The following is a description of a gene set: Human Gene Set: GSE37605_FOXP3_FUSION_GFP_VS_IRES_GFP_TREG_NOD_DN from publication Darce J, Rudra D, Li L, Nishio J, Cipolletta D, Rudensky AY, Mathis D, Benoist C (PMID 22579475) Genes down-regulated in T reg (FOXP3+) cells from NOD mice: Foxp3-Fusion-GFP versus Foxp3-ires-GFP. studied in species Homo sapiens The aim of this study was to quantify the impact of chimeric Foxp3-GFP protein on the Treg cell transcriptional program., and this is the list of marker genes: TMOD3, TTC17, LGMN, KLHDC1 (kelch domain containing 1), PPP1R12B, UACA, GJB3, RTN4RL1, IGFBP4, CDC14B, NCKAP1, THEMIS, TGFBR3, HRH4, PACS1, MYO1F, MRS2, A4GALT, ACP3, SETX, NIPAL1, MTCH1 (NCBI Gene Id 51627), LGALS3, POLG2, ACAP2, NEBL, MUSK, SEC24A (SEC24 homolog A, COPII coat complex component), CYRIA, SMCHD1, MS4A4A, KAT2B, ULK2, LPP, ATP7A, RASIP1, SNAI1, LDLR, MARS2, MUC3A, FLI1, ENTPD5, USP3, ARHGAP15, PDLIM5, RAD54B, SMYD1, MIR145, GPR15, TMPRSS13 (transmembrane serine protease 13), PXYLP1, ADAM12, PRR14, EHBP1L1, SLC38A8, IL1RL1, ATP10D, PITPNC1, RAB4A, KLF3, PTPRA, ANAPC5, SIPA1L1, CCR2, ARMC7, AR, SRSF11, AVEN, CYP2S1, TMC1, ITGAE, GSK3B, PPM1J, PMFBP1, CMA1, CRIP1, ZNRF1, RAP1GAP2, TNNT3, SPN, CAPN2, RPL12, RBMY1A1, IL9R, NSD3, FILIP1L, RAPGEF4 (NCBI Gene Id 11069), CRY1, GABBR1, AHNAK, DOCK10, ZNRF3, FBXL22 (F-box and leucine rich repeat protein 22), SLC4A7, ARHGAP27, LZTS1, CDK16, CAMK4, DIDO1, IKZF1, S1PR1, RAB3IP, TESMIN, SLC22A5, ELF4, GOLM1, ABHD16B, PNMA8A, LANCL3, VSTM2B, RIPOR2, TCL1A, L1CAM, CDKN1B, ROBO1, TXK, MFHAS1 (multifunctional ROCO family signaling regulator 1), POLR3GL, HLF, NAB1, SURF6, TECTA, MLXIP, TMEM71, ATP2B1, MAP4K4, ST8SIA6, TRIM39, BCL9L, RIPOR1, PSMA8, ARID3B, DAPK1, CACNA1I, TREML2, IRAK3, FUT7, SMG1, UBAP2, AXIN2, TXNIP, RORC, VIPR1, DIO1, ITGA2, STOM, AHNAK2, SCN4A, SRCAP, OSBPL3, ARL4C, PRKCQ, ARSB, NLRC3 (NLR family CARD domain containing 3), NSD1, MIR505, SYNE2, RBMS1, CSF2RB (colony stimulating factor 2 receptor subunit beta), TNIK, PRSS12, MB, CACNB1, KCNA2, SLAIN2, RHBDF2, SH2D4B, TMEM176B, PDLIM1, SYT6, PLCD1